The following is a description of a gene set: species: Homo sapiens Human Gene Set: GOBP_PHOSPHOLIPASE_C_ACTIVATING_G_PROTEIN_COUPLED_RECEPTOR_SIGNALING_PATHWAY A G protein-coupled receptor signaling pathway in which the signal is transmitted via the activation of phospholipase C (PLC) and a subsequent increase in the intracellular concentration of inositol trisphosphate (IP3) and diacylglycerol (DAG). IP3 regulates the opening of calcium channels in intracellular calcium store, leading to the release of calcium into the cytosol. Calcium and DAG activate protein kinase C (PKC), which in turn activates downstream effectors., and this is the list of marker genes: CHRM3, AGT, GNAQ, CMKLR1, HTR2A, ORAI1, GPR157, DRD5, OPRL1, GPR143, CHGA, DGKQ, P2RY12, DGKZ, PRKD3, ADGRG2, PIK3CG (NCBI Gene Id 5294), HTR2C, LTB4R, CCKAR, F2, PLCB4, PLEK, TGM2, GNG13, LHCGR, OPRK1, ADGRG1, DRD3, HTR1B, GALR2, PTGER1, CASR, C3AR1, HRH1, PKD2, FSHR, FFAR1, TAAR1, AGTR1, GPR32P1, P2RY4, ANO1, GPR55, DRD2, AZU1, AVPR1B, GPR33 (G protein-coupled receptor 33), MC1R, EDN1, GPR68, TACR1, FPR3, ADRA2A, PLCE1, PTGER3, FPR2, PRKD2, FPR1, NMBR, HTR2B, P2RY2, PRKD1, ACTN2, GPR4, MAS1, DGKB, ITPR1, ADRA1B, PLCB2, TRHR, ABL2, C5AR2, PLCB3, CALCA, FFAR2, NTSR2, C5AR1, LPAR1, S1PR1, NRXN1, DGKA, VEGFA, ESR1 (estrogen receptor 1), PARD3, HOMER1, GRPR, RASGRP4, EDNRA, DGKH, GNB1, CHRM2, DGKG, DGKE, PLCB1, INPP5A, GRM1, SELE, GRM5, OXGR1, WNT5A, PTAFR (NCBI Gene Id 91527), NMUR2, PTH1R, HCRTR2, F2R, GPR139, GNA14, PLPP1, DRD4, OPRD1, IL2, ADRA1D, GPR32, CHRM1 (cholinergic receptor muscarinic 1), RGS2, F2RL3, GNA11, HCRT, MC3R, OPRM1, ADORA2A, DGKK, EDNRB, CCKBR, DGKD, GNA15, GRID1, NHERF1, GPR83, P2RY1, ADRA1A, DGKI, P2RY6, FFAR4, GAP43, BICD1, GRP, PRKCG, CXCR2, GPR27, CX3CR1, PRKCB, PLCH2, P2RY11, NMUR1, DRD1